The following is a description of a gene set: Human Gene Set: MIR3679_5P species: Homo sapiens from publication Chen Y, Wang X (PMID 31504780) Genes predicted to be targets of miRBase v22 microRNA hsa-miR-3679-5p in miRDB v6.0 with MirTarget v4 prediction scores > 80 (high confidence targets)., and this is the list of marker genes: CRCP, SOS2, MIS18BP1, CD5L, ATP10D (ATPase phospholipid transporting 10D (putative)), BAZ2B, ZNF280D, DMXL1 (Dmx like 1), PRELID2, SLC46A3, SGCD, KRIT1, ITGA1, ZNF117, NUSAP1, VNN1, HINFP, ALDH3B1, KIAA0408, TSPYL1, SEL1L, ERP29 (NCBI Gene Id 10961), LUZP2, TDP1, IFITM3, CDC42SE1 (NCBI Gene Id 56882), TEAD1, RFT1, KDSR, IGLL5, TLR6, CNTLN, DISC1, AHNAK (AHNAK nucleoprotein), PEX12, MMRN1, ADORA3, STK4, STXBP5L, IFITM2, ABCA9, MED23, ZNF845, NAIP, RGS6, PDHB, NPL, TMEM33, ODAPH, ADGRL1, ICE2, MAOB, AHR, FGF13, PPP2R2A, HTRA4, OGFRL1, GMCL1, BCAM, COPS3, CHTOP, GTF2H1, USP32, FGF14, SLC30A7, CD2AP, RABL3, DHRS2 (NCBI Gene Id 10202), SYTL2, MACC1, CTSK, BRWD3, TRPA1, NCMAP, SULT2A1